The following is a description of a gene set: species: Homo sapiens Genes up-regulated in bone marrow-derived macrophages at 45 min of stimulation by IL6 and LPS: wildtype versus IL6 knockout. IL-10 or IL-6 stimulation of control 129xC57BL/6 murine bone marrow derived macrophages in the presence of LPS. We used microarrays to detail the global programme of gene expression changes in response to IL-6 or IL-10 stimulation in the presence of lipopolysaccharide. BMDMs were isolated from control, IL-6-/-, and IL-10-/- mice on a 129XBL/6 mixed background mice and differentiated in the presence of CSF-1 for 6-7 days. Cells were scraped and plated in 6 well plates at 2x10e6/well. Cells were washed with complete DMEM and rested for 1-2 hr before stimulation with combinations of IL-10 (10 ng/ml), IL-6 (2 ng/ml) or LPS (100 ng/ml) for 45 min or 180 mins. Complete biological replicates were performed. from publication El Kasmi KC, Holst J, Coffre M, Mielke L, de Pauw A, Lhocine N, Smith AM, Rutschman R, Kaushal D, Shen Y, Suda T, Donnelly RP, Myers MG Jr, Alexander W, Vignali DA, Watowich SS, Ernst M, Hilton DJ, Murray PJ (PMID 17114459) Human Gene Set: GSE5589_WT_VS_IL6_KO_LPS_AND_IL6_STIM_MACROPHAGE_45MIN_UP, and this is the list of marker genes: SCN1B, CIB3, HEXB, PTGIR, CYP24A1, CREB3L3, BCL2A1, MMP13, LYSMD1, MYH10, IRF2BPL, CLNK, CPA6, SYP, CX3CR1, RCAN1, KIT, SPTB, FCGR2B, FAT3, PDE1C, SSTR5, GP2, SEC22C, CAMKK1, SLC39A8, ANKRD34A, KRT15, PF4, CFAP91, NTN1, SPNS3, APC2, CFI, CCR3, RTP3, GUSB, CHRNA9, SPN, DOC2B, CFAP96, ERO1B, ALDH1A3, GABRB1, SBSPON, PRUNE2, SLC18A1, SRPK3, KCNJ9, PRKG1, PRSS50, CD3E, CDCA5, EYA2, RTN1, CYP3A7, NMUR1, ZNF169, GINM1, EDNRB, GARIN4 (golgi associated RAB2 interactor family member 4), PCP4, GPR68, UPK3A, CST7, APP, STMN4, SPEG, TRNP1, EEIG1, SLAMF1, ST7, CA11, PGPEP1L, RPS6KA3, DPP8, C3orf70, SPRR3, SPRYD7, NAPB, FBXL17, RAPSN, SBK1, ARHGEF40, DKK1 (dickkopf WNT signaling pathway inhibitor 1), CPD, TMEM215, SOX1, CSRP3, SPP1, FANCG, FOLR2, GSTO2, VOPP1, ZNF521, RYR1, PRDX1, SDK2, TAF3, RMDN2, C21orf58, PYGB, INSM2, DGKB, DYNC2I2, CRB1, ANGPTL1, RNASEL, TRAK2, CD52, FXYD2, MLXIPL, CEP104, SYT11, BRINP3, FGF19, ARMC3, LRPAP1, GLIPR1, ETS1, CD14, MATN4, INSIG2, NRP1 (NCBI Gene Id 8829), SH2D3C, STK35, ADH1C, C14orf180, CHST7, IRAG1, ITGAX, FAM229B, LYPD8, PODXL, BCL6B, PLK2 (NCBI Gene Id 10769), PROCR, SVOP, ELL2, CUTC, NCF4, CD72, C1QA, LRRC46, NUBP2, IL21R, TENT5C, RHOH, TNK1, TXK, PTPRCAP, EOMES, AFF1, HAND2 (heart and neural crest derivatives expressed 2), FLOT2, RHD, SGMS2, RABGAP1L, CLEC4D, MAN1A1, ATP6V1F, MCUB, STARD3NL, ADH4, ST8SIA2, WTAP, DPYS, KCNK1 (NCBI Gene Id 3775), CD200R1L, PRKCB, NWD1, ATP2A3, NFATC2, EPB41L4A, FBXW11, SSTR2, TMF1, PAPSS2, GATM, WBP11, FAM181B, SULT4A1, LCA5L, SHFL, CAP2, ADAMTS9, ADPRHL1, MAP4K2, MYCN, ALAS2, BBS1, F12, PTX4, MARCKSL1, ESPN, GRM8, CD276, TFPI, CHRNA3